The following is a description of a gene set: Genes positively correlated with high anti-HBs concentration at week 4 post-boost in blood in young/old adults (20-38)/(62-74) (booster vaccination) after exposure to Twinrix, time point 1D. Comment: Correlation between pre-immunization expression levels of single genes (log2-transformed) and anti-HBs concentrations (log10-transformed) at week 4 after booster vaccination species: Homo sapiens from publication Weinberger B, Haks MC, de Paus RA, Ottenhoff THM, Bauer T, Grubeck-Loebenstein B (PMID 29868000) Human Gene Set: WEINBERGER_BLOOD_TWINRIX_AGE_20_40_AND_60_84YO_CORRELATED_WITH_HIGH_ANTI_HBS_CONC_AT_WEEK_4_POST_BOOSTER_VACC_1DY_POSITIVE Many current vaccines are less immunogenic and less effective in elderly compared to younger adults due to age-related changes of the immune system. Most vaccines utilized in the elderly contain antigens, which the target population has had previous contact with due to previous vaccination or infection. Therefore, most studies investigating vaccine-induced immune responses in the elderly do not analyze responses to neo-antigens but rather booster responses. However, age-related differences in the immune response could differentially affect primary versus recall responses. We therefore investigated the impact of age on primary and recall antibody responses following hepatitis B vaccination in young and older adults. Focused gene expression profiling was performed before and 1 day after the vaccination in order to identify gene signatures predicting antibody responses. Young (20-40 years; <i>n</i> = 24) and elderly ( > 60 years; <i>n</i> = 17) healthy volunteers received either a primary series (no prior vaccination) or a single booster shot (documented primary vaccination more than 10 years ago). Antibody titers were determined at days 0, 7, and 28, as well as 6 months after the vaccination. After primary vaccination, antibody responses were lower and delayed in the elderly compared to young adults. Non-responders after the three-dose primary series were only observed in the elderly group. Maximum antibody concentrations after booster vaccination were similar in both age groups. Focused gene expression profiling identified 29 transcripts that correlated with age at baseline and clustered in a network centered around type I interferons and pro-inflammatory cytokines. In addition, smaller 8- and 6-gene signatures were identified at baseline that associated with vaccine responsiveness during primary and booster vaccination, respectively. When evaluating the kinetic changes in gene expression profiles before and after primary vaccination, a 33-gene signature, dominated by IFN-signaling, pro-inflammatory cytokines, inflammasome components, and immune cell subset markers, was uncovered that was associated with vaccine responsiveness. By contrast, no such transcripts were identified during booster vaccination. Our results document that primary differs from booster vaccination in old age, in regard to antibody responses as well as at the level of gene signatures. Clinical: www.clinicaltrialsregister.eu, this trial was registered at the EU Clinical Trial Register (EU-CTR) with the EUDRACT-Nr. 2013-002589-38., and this is the list of marker genes: CD19, CXCR5, CTLA4, CD274, CCR7, IL6